Given this list of marker genes RAPGEF3, CXCL10, MIR515-1, CFLAR, TMEM182, here is a description of the gene set: Any process that decreases the frequency, rate or extent of the formation of a syncytium, a mass of cytoplasm containing several nuclei enclosed within a single plasma membrane, by the fusion of the plasma membranes of two or more individual cells. species: Homo sapiens Human Gene Set: GOBP_NEGATIVE_REGULATION_OF_SYNCYTIUM_FORMATION_BY_PLASMA_MEMBRANE_FUSION